Given this list of marker genes ATF5, BBOX1, PRNP, PRKX, FMOD (NCBI Gene Id 2331), KCNS3, RIPK2, SUCLG2 (succinate-CoA ligase GDP-forming subunit beta), MNAT1, COL3A1, ZWINT, KCTD12, REEP5, PGAM2, FXR1, CD8A, DYRK3, CXCL5, LCP2, HOXB7, ECHS1, BNIP1, MAGEA5P, TMEM47, TMEM131L, PPP2R3A, IRF9, SCD, TRIM25, SLC39A8, ARHGEF10, MED13, CEMIP, DIXDC1, NFIL3, MAL, SPINT2, PCSK5, RASA2, SLA, GNRHR, STC1, PTPN13, ERC2, TAX1BP3, SND1-IT1, RGL1, GIP, TP53BP2, CENPE, TRPC6, LRIG1, BMPR1A, PALLD, CLDN8, UGDH, SMG7-AS1, P2RY14, ARNT, ACD, S100P, PLA2G4C, CD8B, PTPN4, CCR1, STAR, RGS13, BAZ1A, DKK1, TLR3, KDSR, RASGRP1, CBL, CEP112, GUCY1A2, CCDC144A, EVI2B, H2AP, FARP1, TRHR, PTGIR, CASK, ATP6V1H, ACTC1, S1PR1, RHOQ, GALNT10, SOCS1, EMP2, IL1RN, PTPRZ1, TRAF6, PGAP2, PEG3, IL18 (NCBI Gene Id 3606), BCL2L11, TRAFD1, ZNF460, CHL1, XCL2, HSF2BP, IDE, CHST10, ARHGEF17, CD24, GPR107, SYN2, AFF2, S100A11, DGKB, SLC11A2, RPL28, PLPP1, CPE, PLEKHB2, ZFR2, AFP, RFC1, TRIB2, GRM5, RSAD2, EPB41L3, PLCH1, NCF2, LRRN3, CTSS, NXT2, PROX1, IL4R, CD47, BLNK, SLC25A16, WDFY3, ADH1C, PACRG, QSOX1, IL10RA, MAP7, VCAN, POM121L6P, ATP10D, ITPR1 (inositol 1,4,5-trisphosphate receptor type 1), TRIM33, CA6, PANX1, IL4, ABHD5, CPA2, GPR183, PRKG1, ELL2, H1-4, KRT34, RPS6, DARS1 (aspartyl-tRNA synthetase 1), CPM, GYS2, TYRP1, HHLA1, C17orf75, ZFP69B, SRD5A1, MAGEA1, CGA, KCTD17, JADE3, ALDH7A1, OIP5, KLRB1, RBM5, SIRPB1, DMP1, FOXF2, BCL9, FGL2, KRTAP26-1, AQP9, SOS2, YWHAQ, OMD, DYNLT1, TCP10L3, POU3F4, DENND4A, MAP3K14, URB1, KDELR1, ACP3, ANAPC13, ANXA1, CCL15, BAZ2B, SYT1, CHD3, DSG1, SELL, ALB, H2BC21, RGS5, here is a description of the gene set: from publication Rayner KJ, Sheedy FJ, Esau CC, Hussain FN, Temel RE, Parathath S, van Gils JM, Rayner AJ, Chang AN, Suarez Y, Fernandez-Hernando C, Fisher EA, Moore KJ (PMID 21646721) species: Homo sapiens Human Gene Set: GSE28783_ANTI_MIR33_VS_UNTREATED_ATHEROSCLEROSIS_MACROPHAGE_DN Inhibition of miR-33 results in increased cholesterol efflux and HDL-cholesterol levels in mice. In this study we examined the effect of miR-33 inhibition in a mouse model of atherosclerosis and observed significant reduction in atherosclerotic plaque size. At the end of the study, gene expression in macrophages from the atherosclerotic plaques was assessed. The results demonstrated a reduction in inflammatory gene expression and increased levels of mRNAs containing miR-33 binding sites. Genes down-regulated in atherosclerosis macrophages: anti miR-33 versus untreated.